Given this list of marker genes PROC, F5, PROS1, here is a description of the gene set: Reactome Pathway: Defective cleavage of FV variant at R334 part of: Defective FV causes thrombophilia  species: Homo sapiens Under normal physiological conditions, activated protein C (APC) regulates clotting by cleaving factor Va (FVa) at residues R534 and R334, thereby preventing excessive clot formation. This disrupted FVa proteolysis leads to prolonged clotting activity of FVa, potentially increasing the risk of venous thromboembolism (VTE) in individuals carrying either of these mutations (Williamson D et al., 1998; Franco RF et al., 1998; Norström E et al., 2002; Mumford AD et al., 2003; Steen M et al., 2004; reviewed by Moore GW et al., 2023).